The following is a description of a gene set: from publication Caffarel MM, Moreno-Bueno G, Cerutti C, Palacios J, Guzman M, Mechta-Grigoriou F, Sanchez C (PMID 18454173) Genes down-regulated in EVSA-T cells (breast cancer) treated THC (delta-9-tetrahydrocannabinol). Human Gene Set: CAFFAREL_RESPONSE_TO_THC_DN species: Homo sapiens It has been recently shown that cannabinoids, the active components of marijuana and their derivatives, inhibit cell cycle progression of human breast cancer cells. Here we studied the mechanism of Delta(9)-tetrahydrocannabinol (THC) antiproliferative action in these cells, and show that it involves the modulation of JunD, a member of the AP-1 transcription factor family. THC activates JunD both by upregulating gene expression and by translocating the protein to the nuclear compartment, and these events are accompanied by a decrease in cell proliferation. Of interest, neither JunD activation nor proliferation inhibition was observed in human non-tumour mammary epithelial cells exposed to THC. We confirmed the importance of JunD in THC action by RNA interference and genetic ablation. Thus, in both JunD-silenced human breast cancer cells and JunD knockout mice-derived immortalized fibroblasts, the antiproliferative effect exerted by THC was significantly diminished. Gene array and siRNA experiments support that the cyclin-dependent kinase inhibitor p27 and the tumour suppressor gene testin are candidate JunD targets in cannabinoid action. In addition, our data suggest that the stress-regulated protein p8 participates in THC antiproliferative action in a JunD-independent manner. In summary, this is the first report showing not only that cannabinoids regulate JunD but, more generally, that JunD activation reduces the proliferation of cancer cells, which points to a new target to inhibit breast cancer progression., and this is the list of marker genes: CDK1, DNAJA1, UBAC1, MCM3, TUBA3C, TUBB, ZWINT, DHFR, PNP, SERPINB2, SPIDR, RBM4, DHCR7 (NCBI Gene Id 6589), UHRF1, PPIF, MCM6, HSPA2, GIPC1, CCNA2, RRM2, TMEM109, HSPA8, HSPH1, CYP51A1, EBP, SESN1, EIF1AXP1, PCLAF, TUBA1A, PABPC4, SRSF3, CALM3